The following is a description of a gene set: Genes having at least one occurrence of the motif TATAAATW in the regions spanning 4 kb centered on their transcription starting sites. This matches the TBP transcription factor binding site V$TBP_01 (v7.4 TRANSFAC). Human Gene Set: TBP_01 species: Homo sapiens, and this is the list of marker genes: ATXN7L1, FOXN3, CCDC140, NDRG2, TSC22D1, POU4F1, SLC25A4, ANKS1B, PPP1R3A, AOC2, MEIS1, ENSG00000291228, LPAR4, PANK1, SULT2A1, ITGA7, EHD1, ABR, NR0B2, RAB5B, P2RX5, CLDN23, MAT2A, CPA4, SEMA4B, PRKAA2, GCG, HRC, CCL23, RTL9, FGF5, FXYD1, NR4A1, TUBA4A, SOX9, CSDE1, TEF, DIRAS1, RIT1, RXFP2, ADAM11, GSC, SH3GLB2, MYOCD, BEX2, NOS1AP, PPP2R2A, ANGPT4, LRRTM3 (leucine rich repeat transmembrane neuronal 3), HOXA10, DKK4, KLHDC8B, LUC7L, H2AC1, MIR503HG, H1-1, TAX1BP3, RILP (Rab interacting lysosomal protein), HDAC7, ASB16, HDAC9, ART3, CTNNAL1, CLCN1, PTF1A, H2BC21, WWC2-AS2, PATZ1, ASB5, POFUT1, DES, CDH20, SLC30A1, OGFOD1, CSNK1E, ZNF436-AS1, SH3BGRL3, CBLN4, EGR2, PRKAG1, H2BC1, IGSF21, SECISBP2L, CYP26B1, ACYP2, LGALSL, KRT222, NDST4, TLK1, TRIM63, RARA, RPS19, RCOR1, TMEM86B, TRDN, CPNE1, XK, CTCF, SLC26A9, ZFP36L1, CRISP1, NNT, AMPD1, GALNT1 (NCBI Gene Id 2589), ADGRD1, ABCC6, DNAJA4, TMEM88, ART5, DMPK, ZKSCAN5 (NCBI Gene Id 23660), AQP1, DMD, GPR153, ESRRG, FBXW11, H2AC21, CKB, DLG2, ELMO1, MAP2K5, EMC6, CDC42EP3, IFNB1, HAND2, SLC35C2, SUPT4H1, SSH3, LHX5 (NCBI Gene Id 64211), NR0B1, C12orf57, SCHIP1, GABRB2, TSPEAR, LYPD1, AMDHD2, ATXN1, SKIDA1, SYTL2 (synaptotagmin like 2), PACSIN3, PPARGC1A, CELF4, WIPI1, GPBP1L1, KAT7, ASB18 (ankyrin repeat and SOCS box containing 18), B3GALT6, TECR, CLRN1, CUL3, TNFRSF17, THBS2, MACO1, RTL3 (NCBI Gene Id 203430), FOS, ZC3H10, PLA2G4B, KCTD15, EPHA7, LGI1, H2AC20, CFL2, PMEPA1, ACTA1, PLAGL2, TPM2, PLEC, KPNA3, RHOBTB1, SOX5, HNF1A, TMEM117, S100A4, TTC17, USP47, KRT26, SLC3A1, CELF3, TUBA4B, PATE1, NRN1L, NAT8L, LINC01597, PNMA1, PAX3, COL1A2, IGSF9B, TSC1, C10orf71, BRAF, NOS2, NOG, ASB4, GRIN2B, FGF21, MEOX2, TRPM4, SLC35F5, IGF1, DYRK2, GDPD3, SLC2A4, MYH8, RASGRP3, HOXB5, NANOS1, PAK6, HBEGF, FAM78A, FZD8, HOXC4, CPEB4, GIT1, TMEM178A, AGT, LINC00670, ZNF436, GRIK4, CHMP1B, SERPINB13 (serpin family B member 13), MGAT3, ANKRD23, CCL15, NME5, KBTBD12, BNC2, HOXB4, SPTB, SRSF3, HOXC6, NTF3, CHRDL1 (chordin like 1), HOXC5, LBX1, ABLIM1, TSPAN13, MSC, STAC, DNM2, NCOR1, COL10A1, HSPB3, EN1, FHL2, HAPLN1, COL13A1, BICD1, ITGB3BP, FLI1